The following is a description of a gene set: Human Gene Set: PAF1_TARGET_GENES species: Homo sapiens Genes containing one or more binding sites for (PAF1) in their promoter regions (TSS -1000,+100 bp) as identified by GTRD version 20.06 ChIP-seq harmonization. from publication Yevshin I, Sharipov R, Kolmykov S, Kondrakhin Y, Kolpakov F (PMID 30445619), and this is the list of marker genes: CCNDBP1, LHFPL4, PABPC4, EFNA1 (ephrin A1), BSCL2, ZC3H10, SUZ12P1, EXOSC6, SCAMP3, RALBP1, RNA5SP60, LINC01719 (NCBI Gene Id 101928979), MRPL33, GLRA1, B4GAT1, SPATA1, IMPA1, MAPK11, UBE2Z, NRAS, ACIN1, POLB, SNORD118, CFAP53, HTR5A, SCRT1, MIR7-3, PKD1P3, ARSB, KCNH6, OXNAD1, ERICD, STX16-NPEPL1, RAD23B, AGO2 (NCBI Gene Id 286109), MIB2, PMF1-BGLAP, CCDC34, SEMA4B, IMPDH2, PMF1, MIR6770-1, CIRBP, APOA2, MSTO1, CYP21A1P, CD68, MIR7-3HG (NCBI Gene Id 284424), TMEM191B, SNORD13, TRIM73, TCAF1, B4GAT1-DT, ESYT1, DAGLB, NPIPA9, ABCA7, TARDBP, EIF2AK4, CYP19A1, SNORD3A, KLF6, DPH3, CNOT6, BARHL1, MEIS2, CLASP1, SLC50A1 (NCBI Gene Id 55974), MAPK8IP2, FAM3A, SNX18P23, TTLL5, OLFML3, TTI2, PLCXD1, STX16